The following is a description of a gene set: from publication Liberzon A, Birger C, Thorvaldsdóttir H, Ghandi M, Mesirov JP, Tamayo P (PMID 26771021) A subgroup of genes regulated by MYC - version 1 (v1). studied in species Homo sapiens Human Gene Set: HALLMARK_MYC_TARGETS_V1, and this is the list of marker genes: RANBP1, XPOT, CCNA2, PPIA, TARDBP, RAD23B, MCM4, CANX, EIF4G2, ERH, SET, NOLC1, RPL6, TRIM28, EIF2S1, RPL34, PSMD1, HDAC2, CDC45, RAN, MRPS18B, YWHAQ, SYNCRIP, VDAC3, SF3B3, NOP16, RPS3, GOT2, NME1, SRM, FAM120A, PCNA, CUL1, POLE3, PSMC6, CDK2, HNRNPA2B1, TXNL4A, ABCE1, ETF1, COPS5, PSMA4, YWHAE, TOMM70, DDX18, PRPF31, EIF3B, FBL, PGK1, CTPS1, PABPC1, SNRPD1, HSPE1, RRP9, DUT, RUVBL2, EIF4H, GLO1, DHX15, SSBP1, C1QBP, SMARCC1, UBE2E1 (ubiquitin conjugating enzyme E2 E1), UBE2L3 (NCBI Gene Id 7332), RNPS1, KPNA2 (NCBI Gene Id 728860), SF3A1, EIF4E, PSMA1, PSMC4, G3BP1, HSPD1, PRDX3, PABPC4, PSMA7, PRDX4, CYC1, SRSF7, RPS6, SNRPB2, HSP90AB1, MRPL9, HNRNPD, NHP2, NOP56 (NCBI Gene Id 10528), PSMD8, PSMD7, HDDC2, LSM2, SNRPA, RPL22, NAP1L1, GSPT1, BUB3, KPNB1, RPS10, CCT5, PSMD3, MCM2, DDX21, SSB (small RNA binding exonuclease protection factor La), VDAC1, PA2G4, EIF2S2, CNBP, NCBP1, ILF2 (NCBI Gene Id 3608), PSMA2, MAD2L1, RPLP0, PSMA6, U2AF1 (NCBI Gene Id 7309), IFRD1, SNRPD3, RPS2, AP3S1, RPL14 (ribosomal protein L14), CBX3, MCM7 (minichromosome maintenance complex component 7), HNRNPC, SERBP1, RSL1D1, SNRPG, RRM1 (ribonucleotide reductase catalytic subunit M1), COX5A, DEK, KARS1, IMPDH2, HDGF, NDUFAB1, CAD, HNRNPU, CDC20, CCT2, TFDP1, ODC1, HNRNPA1, PRPS2, CLNS1A, PSMB2 (NCBI Gene Id 5690), NPM1, PHB1, TUFM, SRSF2, H2AZ1, XRCC6, MCM5, USP1, EIF3D, LSM7, GNL3, EIF3J, STARD7, EIF4A1, PSMB3, UBA2, MRPL23, NCBP2, TYMS (thymidylate synthetase), TCP1, RPS5, PCBP1, HPRT1, TRA2B, SRSF3, VBP1, EEF1B2, PSMD14, EIF1AX, HNRNPA3, POLD2, RPL18, SLC25A3, CSTF2, IARS1, CCT3, MYC, SNRPA1, CCT7 (chaperonin containing TCP1 subunit 7, NCBI Gene Id 10574), SRPK1 (NCBI Gene Id 6732), EXOSC7, CCT4, LDHA, PTGES3, PWP1, RFC4, AIMP2, HNRNPR, XPO1, ACP1, EPRS1, SRSF1, RACK1, SNRPD2, MCM6, APEX1, CDK4, ORC2, PHB2, PPM1G